Given this list of marker genes RRAGC, HBB, NAGA, ASXL1, RNU7-1, MYBPC3, ENPP1, MYLK, PLAGL1, PLXND1, ABCC6, GATB, NAGLU, TBL2, TRIM37, RNASEH2B, CACNA1C, AARS2, IFIH1, ELN, SLC17A5, RFC2, ESAM, ACTN2, LIMK1, THSD4, NIPBL, BAZ1B, PGM1, CLIP2, MT-CYB, BUD23, TGFBR2, FUCA1, NDUFB7 (NADH:ubiquinone oxidoreductase subunit B7), JUP, EIF4H, LOX, FOCAD, ACADVL, TGFBR1, IGF2, GTF2IRD2, LYN (NCBI Gene Id 4067), GBA1, HYMAI, PIGS, NKX2-6, NCF1, B3GAT3, SLC22A5, HEXB, SMAD2, NAA10, DES, LAMP2, SCO2, HFE, ALPK3, WDR37, NHLRC2, FBN1, STAT2, COX6B1, GTF2IRD1, NDUFC2, TTR, CPT2, RNASEH2C (NCBI Gene Id 84153), DYSF, KCNQ1OT1, VPS37D, LSM11, SDHA, CPT1A, MOGS, GNPTAB, VAC14, TET3, CLIC2, CLXN, FHL1, PHYH, ADAR, ZIC3, FKBP6, MYH11, TMEM270, METTL27, PRKAG2, BMP2, SAMHD1, NEK9, NEU1, ACADM, COX5A, SMAD3, PEX7, FIG4, RNASEH2A, KCNJ8, TGFB2, MTTP, ACTA2, TBX1, MAT2A, FOXE3, DOHH, CDKN1C, TGFB3, BMP6, NONO, PAM16 (NCBI Gene Id 51025), SMAD4, C1QBP, ABCC9, MFAP5, PSMB9, HEY2 (NCBI Gene Id 30830), TREX1, GTF2I, PSMB8, HSD17B10, APOA1, MTO1, DSP, SLC29A3, TAPT1, CHST3, GAA (NCBI Gene Id 2548), STX1A, KCNQ1, PRKG1, SLC31A1, PRKAR1A, DNAJC30, here is a description of the gene set: species: Homo sapiens Human Gene Set: HP_CARDIOMEGALY Cardiomegaly Increased size of the heart, clinically defined as an increased transverse diameter of the cardiac silhouette that is greater than or equal to 50% of the transverse diameter of the chest (increased cardiothoracic ratio) on a posterior-anterior projection of a chest radiograph or a computed tomography.